Given this list of marker genes Ngfr, Traf6, Aph1a, Adam17, Psen1, Nfkb1, Ncstn, Aph1b, Psenen, Rela, here is a description of the gene set: species: Mus musculus Regulated proteolysis of p75NTR Mouse Gene Set: REACTOME_REGULATED_PROTEOLYSIS_OF_P75NTR